Given this list of marker genes LRP5, TRAPPC2, CILK1, DYM, RMRP, HRAS, RAB33B, MYH3, EIF2AK3, COL2A1, LBR, WNT7A, ACP5, TRIP11, TNFRSF11B, COL13A1, VPS33A, KDELR2, CHST3, FUCA1, P3H1, TRPV4, ACAN, here is a description of the gene set: Human Gene Set: HP_BARREL_SHAPED_CHEST studied in species Homo sapiens A rounded, bulging chest that resembles the shape of a barrel. That is, there is an increased anteroposterior diameter and usually some degree of kyphosis. Barrel-shaped chest